The following is a description of a gene set: Any process that modulates the frequency, rate or extent of CAMKK-AMPK signaling cascade. studied in species Homo sapiens Human Gene Set: GOBP_REGULATION_OF_CAMKK_AMPK_SIGNALING_CASCADE, and this is the list of marker genes: HTT, LRRK2, PCP4, MYH7B, TREM2